The following is a description of a gene set: Genes up-regulated in macrophages (12h): control versus IFNG, TNF and rosiglitazone. Human CD14 positive monocytes were purified from healthy volunteers’ blood and cultured in vitro for 4, 12, 24, 72 hours. While culturing, macrophages were activated alternatively with interleukin-4 (IL-4 100 ng/ml) or classically with interferon-gamma (IFNg 100 ng/ml)+tumor necrosis factor (TNF 50 ng/ml) or left without activation. Simultaneously, macrophages were also treated with vehicle (DMSO:ethanol) or 1mM synthetic PPARg agonist, Rosiglitazone. We used Affymetrix microarrays (U133Plus 2.0) to analyze activation and PPARg-induced gene expression changes. species: Homo sapiens Human Gene Set: GSE16385_UNTREATED_VS_12H_ROSIGLITAZONE_IFNG_TNF_TREATED_MACROPHAGE_UP from publication Szanto A, Balint BL, Nagy ZS, Barta E, Dezso B, Pap A, Szeles L, Poliska S, Oros M, Evans RM, Barak Y, Schwabe J, Nagy L (PMID 21093321), and this is the list of marker genes: IER2 (immediate early response 2), TMEM243, DPYSL3, AGRN, CCNL1, FASLG, TNRC6A, CACNG7, DNAJB1, AQP9, KLK9, C1R, SCN3A, HSPA1L, CSF3, PTPN23, MME, PCDH9, YRDC, TNFRSF1B (NCBI Gene Id 7133), GPR171 (NCBI Gene Id 29909), LIMA1, SLC6A18, ZRSR2, MAD2L1BP, MAFF, C14orf28, GRHL3, CEND1, EDA2R, BCL2L2, NR4A1, NICOL1, PEBP4, ERO1B, TRO, SLC18B1, CCR4, GMPPB, C21orf91, HLF, EGR2, POF1B, KBTBD2, ITPRIP, FTMT, GATA3, HSPB3, NAB2, PROM1, ITPKB, EVI2A, TRIM46, PER3, SLC27A2, CACNA1S, ZFP36, PPP1R11 (NCBI Gene Id 9160), SAG, CD93, RINL, HAS1, ADGRE1, DUSP5, CPEB3, KRTAP4-6, JRK, JAM2, CA1, RPL3L, JUNB, CD69, ASIC5, USH2A, DUSP6, TFF3, ARIH2OS, C20orf96, NFKBID, TOMM34, GLRA3 (glycine receptor alpha 3), CDKN2B, STK17B, TM6SF2, TCFL5, ID3, HS6ST3, FBXO8, GML, GARIN1B, PTGER2, ANXA9, CCL4, TDRD1, PRKAB1, MALT1 (MALT1 paracaspase), CCN4, LAMP5, ZFP36L1, IKZF2, SRPRA, IL34, LAMTOR1, ATG101, BTG3, PLK3, OPALIN, IFNB1, KIF26A, GABRG3, GSKIP, TMCC2, ZFAND5, ADAD1, VAMP3, GLIPR1, LRFN2, STX19, PRKAB2, PDCD1LG2, LAMA1, COL5A2, RANBP17, TWF1, TRIM13, S100A5, PABIR1, TBC1D32, EGR3, MLLT11, TGIF2, RANBP6, CD274, GFI1, NR4A2, EXOSC10, FASTKD5, GRAMD2B, ADO, LENG9, ARL5B, KCNQ5, KCNS3, MYH11, GSC, TUT1, UPB1, DCT, NFKBIZ, LRRTM4, RNASE10, FILIP1L, EIF1B, PRDX6, EGR1, CUL9, NFIB, RAB3A, NTSR2, EXOSC3, RASL10A, LYPLAL1, SYT6, C16orf90, VN1R5, PHF6, PDILT, GJB5, MYOD1, DUSP2, ACSM1, CHRM4, ELP5, SPINK4, RCHY1, NCOA7, WWOX, NPAS2, TSPYL4, C2orf88, HOXB3, SRFBP1, SPATA6L, FNDC5, LRRC10B, SHROOM1, TTC19, ZEB1, APOA5, TMEM47, PER1, FAT2, ZNF622, SH2D2A, ANKRD42, SV2A, CEP135, SPESP1, BCL2, B3GAT3